The following is a description of a gene set: species: Mus musculus Mouse Gene Set: GOBP_POSITIVE_REGULATION_OF_GASTRULATION Any process that activates or increases the frequency, rate or extent of gastrulation., and this is the list of marker genes: Osr1, Foxa2, Scx, Rack1, Osr2, Otx2, Tenm4, Lhx1 (LIM homeobox protein 1)